Given this list of marker genes TBX4, MID1, PTRH2, TWIST2, FGD1, ORC1, EFNB1, ATRX, TMCO1, NSUN2, HNF1B, TBX3, LHX1, METTL23, CREBBP, DYRK1A, MED12, NEXMIF, MEGF8, SPECC1L, PSMD12, EP300, SAMD9, LAMA5, SRRM2, here is a description of the gene set: studied in species Homo sapiens Shawl scrotum Human Gene Set: HP_SHAWL_SCROTUM Superior margin of the scrotum superior to the base of the penis.